The following is a description of a gene set: Human Gene Set: GSE44649_NAIVE_VS_ACTIVATED_CD8_TCELL_UP MicroRNA-155 (miR-155) is upregulated in primary effector CD8 T cells but is expressed at low amounts in naïve cells. Anti-viral CD8 T cell responses and viral clearance were impaired in miR-155 deficient (bic-/-) mice, and this defect was intrinsic to CD8 T cells, as adoptively transferred bic-/- CD8 T cells generated greatly reduced primary and memory responses during infection. To understand the mechanism by which miR-155 regulates CD8 T cell activation, we analyzed the gene expression profiles of naive and in vitro activated wild-type and bic-/- CD8 T cells. from publication Gracias DT, Stelekati E, Hope JL, Boesteanu AC, Doering TA, Norton J, Mueller YM, Fraietta JA, Wherry EJ, Turner M, Katsikis PD (PMID 23603793) studied in species Homo sapiens Genes up-regulated in CD8 T cells: resting versus activated., and this is the list of marker genes: WIPI2, GPR19, RNF167, ANAPC13, TSSK1B, TGFBR2, TBXA2R, SUMF1, CUEDC2, LAGE3, VARS1, UNC119B, KLK8, LYRM2, MRPL2, PEX11B, UBAC2, EEF1AKMT1, TRAF5, ANP32A, PEX6, CSNK1G2, PCDH12, REX1BD, PARP6, PDCD1, MATK, RNF141, LDAH, RTN1, DALRD3, TSHB, MYL12B, CHRM4, TK1, MAST3, TMEM71, CDC34, CRYGA, PARK7, ADARB1, ING1, MT3, IGFBP1, MTERF2, PEX2, GCOM1, GNE, DCPS (decapping enzyme, scavenger), SEC61B, BSCL2, ANXA7, CAMLG, PCK2, CAPN5, MPL, PADI2, NCBP2AS2 (NCBI Gene Id 152217), TMEM245, WDFY2, FARSB, TBXT, MRPL44, PAFAH2, ADRA1A, TXNRD1, FYTTD1, SERPINI1, MXD4, ZDHHC14 (zinc finger DHHC-type palmitoyltransferase 14), SEPTIN9, TSC22D1, EIF2B4, MFAP2, CCNB1IP1, CDK5RAP3, DYRK1B, PPDPF, ARHGAP9, PAN2, ACSS1, TGDS, RREB1, CACNG2, TMEM179B, PCSK5, APOD, PI4K2A, SCG2, STK19, NIN, CCNJ, DOCK2, AKTIP, RPL3, NMI, LANCL1, ING4, S1PR4, SIRT3, MRPL40, RBM38, TMEM230, POLD4, TRAF3IP2, RFLNB, NRBP1, LYSMD1, PGLS, CRTAP, CD47, TAF1B, SUN1, OAZ2, ZBTB12, CALCR, ANAPC2, RNASEH2C, ZNF692, PIGU, YPEL3, FOXC1, NAA10, GIMAP1, WDR6, FUCA1, PLD4, NDUFV1, FBXW4, MYO1C, IKBKE, STXBP2, ORMDL3, AKR1A1, XPNPEP1, HPCAL1, SRCAP, HINT1, CFAP20, POLR2G, CUX2, TLR6, TIRAP, TH, CCDC6, ASNSD1, ANAPC5, EPS15L1, MAPK14, ANAPC1, ERCC4, CPT2, HTATIP2, CCNG2, VAC14, ACP6, IGBP1, GDPD3, GALNT1, GLO1, ATG16L1, ENTREP3, EXT2, IL12A, CLEC4F, TSPAN12, HSBP1, TALDO1, STK38, NGRN, RPP21, SGPP1 (sphingosine-1-phosphate phosphatase 1), TSPO, XPC, STX7, DNAJC10, IL10RA, HLA-DMA, DDT, PSPH, TSFM, RDH5, PSMB8, BFSP1, NTPCR, MMP11, MVD, SELENOH, CHGA, AUP1, IL12RB1, ENO3 (NCBI Gene Id 2027), PTGIR, RTL8B, DCTN5, EVL, CAPN7, GTF2I, PDLIM1, ZSWIM7